The following is a description of a gene set: The transcription factor Foxp3 is usually considered the master regulator for the CD4+CD25+ from publication Hill JA, Feuerer M, Tash K, Haxhinasto S, Perez J, Melamed R, Mathis D, Benoist C (PMID 18024188) Genes up-regulated in comparsion of WTActCD4 versus WTActCD4TGF (see Fig. 1 in the paper for details). species: Homo sapiens Human Gene Set: GSE7460_CTRL_VS_TGFB_TREATED_ACT_FOXP3_HET_TCONV_UP, and this is the list of marker genes: IER3, TMEM41B, SNX25, METRNL, FDPS, TPST1, IDH2, ABHD17C, SAP30, ITGB5, OSTC, GLT8D1, HILPDA, ITGB3, FAM117B, DCUN1D5, HBS1L, CLYBL, SOS2, RAPGEF1, UBE2D3, GTF2E2, MDM2, MAFG, CASKIN2, ACADSB, ZAP70, LRP10, LSS (NCBI Gene Id 4047), CST7, IPO5, FOSL2, AK4, TDRKH, PRPF38A, SMARCA5, YIF1A, ATP2A2, FADS2, CHST6, FZD7, GARIN3, ID2, EIF2S2, SORCS3, STX7, CPSF6, SUCNR1, SEC63, ADORA2B, ACACA, NUP54, TAF5, HSPA13, HK2, UBE2QL1, CCL28, ALDOA, HIF1A, PPP2R3C, SLC19A2, DDX11, ZBTB7B, SDHD, P4HA2, NUDCD3, F2RL2, PCBP2, CHSY1, XPO6, RAB9A, FOXK2, OR52N4, CHAC2, DENND2D, PAFAH1B1, MIA2, FAM185A, CDC37L1, PGAP6 (NCBI Gene Id 64731), PHF10, LACTB2, AGBL4, IMMT, PLXNC1, YME1L1, ADAM8, LMLN, TCERG1, REV1, CCNT1 (NCBI Gene Id 904), SIAH2, ASXL3, CHADL, GAK, ECHDC1, FLVCR1, ABCC1, SSR3, CNEP1R1, ATF2, PCYT2, TMEM183A (transmembrane protein 183A), GPNMB, CABYR, SLC3A2, LONP1, ZNF639, PIGU (phosphatidylinositol glycan anchor biosynthesis class U), PTP4A2, PGAM1, SLC38A1, RSBN1, LMAN1, PTCD3, AFG3L2, SLC31A1, PSMC6, PAFAH1B2, INSIG1 (insulin induced gene 1, NCBI Gene Id 3638), TUT1, SYNCRIP, SEC61A2, DGKI, ORC1, SLC39A7, PLIN2, LAMA3, IL2RB, RAD54L2, TMED10 (NCBI Gene Id 10972), DBF4, PANK3, COX18, MED12L, CYB5B, CD28, PCCA, JMJD6, SNX9, SCCPDH, ATF4, APOL2, SLC2A1, CEP83, HSPA4, POLR2D, KCNK5, TICRR, SLC30A4 (NCBI Gene Id 7782), PTOV1, ICAM2, RASGRF1 (Ras protein specific guanine nucleotide releasing factor 1), NARS1, C1orf52, YARS1, SMIM5, FAM210A, LRP8, PPP3R1, CDV3, FBXO46 (NCBI Gene Id 23403), VAV3, KSR1, BAZ1A, GPI, PROSER1, GCNT7, TFAP4, TMEM39A, LPAR4, PRDM1, ALG11, GORASP2, CA12, SETDB1, ANKRD46, RAD50, KPNB1, PDXP, MMS22L, EED, PTBP1, CCT4, DNAJC21, EGLN3, UNC119B, ELANE, WAPL, LELP1, SEC61A1, HDDC2, RYK, AKT1, EMILIN2, EZH2, DUSP16, WSB2, TUFM, HCFC1